Given this list of marker genes KCNJ15, KCNJ12, GNG8, GNG12, KCNJ14, KCNJ5, GABBR2, GNB4, KCNJ11, GABBR1, ABCC8, GNG13, GNG7, GNB3, GNG5, GNB5, GNGT1, KCNJ6, GNG3, KCNJ9, GNG10, KCNJ8, KCNJ4, GNGT2, ABCC9, GNG2, GNG11, KCNJ10, KCNJ1, GNB1, KCNJ3, GNB2, KCNJ16, KCNJ2, GNG4, here is a description of the gene set: Inwardly rectifying K+ channels (Kir channels) show an inward rather than outward (like the voltage gated K+ channels) flow of K+ thereby contributing to maintenance of resting membrane potential and regulation of action potential in excitable tissue. Kir channels are found in a variety of cell types such as cardiac myocytes, neurons, blood cells, osteoblasts, glial cells, epithelial cells, and oocytes. Kir channels can be functionally divided into ATP sensitive K+ channels (Kir 6.1 and Kir 6.2), classical kir channels (Kir 2.1, 2.2, 2.3, 2.4, 5.1) G protein gated K+ channels (Kir 3.1, 3.2, 3.3, 3.4) and K+ transport channels (Kir1.1, 7.1, 4.2, 4.1). species: Homo sapiens Reactome Pathway: Inwardly rectifying K+ channels part of: Potassium Channels